The following is a description of a gene set: Catalysis of the reaction: estradiol-17-beta + NAD(P)+ = estrone + NAD(P)H + H+. The activity can use NAD+ or NADP+ as the acceptor. species: Mus musculus Mouse Gene Set: GOMF_ESTRADIOL_17_BETA_DEHYDROGENASE_NAD_P_PLUS_ACTIVITY, and this is the list of marker genes: Akr1b7, Akr1b10, Hsd17b3, Hsd17b6, Hsd17b12, Hsd17b8, Akr1c6, Hsd17b1, Hsd17b13, Hsd17b10, Akr1b8, Dhrs11, Hsd17b14, Hsd17b4, Hsd17b11, Hsd17b7, Hsd17b2